The following is a description of a gene set: A process that increases synaptic plasticity, the ability of synapses to change as circumstances require. They may alter function, such as increasing or decreasing their sensitivity, or they may increase or decrease in actual numbers. species: Homo sapiens Human Gene Set: GOBP_POSITIVE_REGULATION_OF_SYNAPTIC_PLASTICITY, and this is the list of marker genes: NEUROD2, ADCY8, EPHB2, CFL1, MAP1B, CDC20, CPLX2, SSH1, ANAPC2, DBN1